Given this list of marker genes FSTL5, GLCCI1, TAB2, STX2 (syntaxin 2), ZDHHC22, ABHD4, ERG, GOSR1, ARSJ, UNC80 (unc-80 homolog, NALCN channel complex subunit), LENEP, SP1, RAB5B, ABRAXAS2, PGS1, RNF13, CHRNA1, PCDHGB5, RIMS1, USP49, DEPDC5, OVOL2, SLC5A9, BTF3L4, ABL1, ZNF500, GID4, RPRD1A, ZFX, PIP4K2C (phosphatidylinositol-5-phosphate 4-kinase type 2 gamma), RNF11, TM2D3, NAP1L1, RNF130 (ring finger protein 130), HNRNPH1, KCNMB4, EMILIN3, TES (testin LIM domain protein), PTPRG, ANKH, RIC3, USP1, CD47, RXRB, ARHGAP35 (Rho GTPase activating protein 35), RNF214, CKS1B, HDDC3, CNGA2, ARSD, RAB10, SHC1, SRPK1, B4GAT1, JARID2, TNPO1, GAGE1, PGAP1, MAGI3, SPSB1, YTHDF3, TRPC5, GPATCH2L, PRKD2, PCDH19, SPMIP8, ARL15, TNRC6B, ESYT2, GALT, TNRC6A (trinucleotide repeat containing adaptor 6A), C10orf105, FKBP3, ARPP19, RBMS3, LSM10, AKAP13, TP53 (tumor protein p53), ARL10, RPAIN, TCF12, ZNF451, CYP4F11, MARCHF8, TRHDE, TLCD2, SEC61A1, LINC02953, ANKIB1, BCL11A, CASTOR2, CIT, MAP2, PLA2G4C, PTPRT, BTG1, PAX5, ERC1, NIP7, KIF1B, FUT4, BUB1B, VPS37C, RFK, here is a description of the gene set: Human Gene Set: MIR3922_5P species: Homo sapiens from publication Chen Y, Wang X (PMID 31504780) Genes predicted to be targets of miRBase v22 microRNA hsa-miR-3922-5p in miRDB v6.0 with MirTarget v4 prediction scores > 80 (high confidence targets).